Given this list of marker genes BRIX1, ASB8, PRELID2, SMPD4, ENOPH1, EXOSC3, CHIA, TMEM100, CTPS1, FUT11, HCAR2, ARV1, SERPINF1, KBTBD7, TNK1, ABCB6, GPR83, MRPL22, COQ4, YRDC, MT2A, NHLRC2, BTK, ATAD1, GPR89B (G protein-coupled receptor 89B), IVD, ECD, ZNRD2, MKX, PDCD1, DRC12, CLCN4, PES1, POLR3E, BOD1, VDAC1, CUL5, RWDD4, RBMXL1, MFSD3, HDAC3, MOBP, ZNF638, RNF113A, IMPG1, JCAD, PCLAF, PLEKHA6, QNG1, C1S, PRMT7, GPR37L1, C1orf216, TXNL4A, RBBP4, PAPOLA (NCBI Gene Id 84718), PFN1, RBBP7, DLD, POLA2, PDF, HDAC1, FGFBP1, NRSN1 (neurensin 1), LIPT1, COL6A5, SOCS1, LIPT2, FEN1, LTB, MTF2, POP7, YTHDC2, TFAP2E, DEFB119, NDUFAB1, OTOP2, TMTC4, HPRT1, AKR7A2, HASPIN, SLC39A1, MRPL19, RUVBL2, SLC2A3, ORC6, IRGM, ERG28 (ergosterol biosynthesis 28 homolog), UBL3, C6orf58, LYAR, CCDC86, WDR77, SOWAHC, DBR1, PPP1R7, EXOSC1 (exosome component 1), SLC30A2, B3GNT2, SRSF6, PSMC2, POLR2D, SUV39H2, BCKDK, LIG1, RARS1, EIF5A2, ORAI1, TP73, RPUSD3, TYSND1, USP39, C5orf47, USP1, PRMT5, IPO11, SLF1, CDC34, CHAC2, RNF180, CRLF3, EIF4A1 (eukaryotic translation initiation factor 4A1), TBRG4, PRKAG2, MGAT3, CIMIP5, LIPG, ANXA4, TUBA4A, ZNF81, BCL2A1, SBNO1, PLCD1, TFAM, POLR1E, HEBP1 (heme binding protein 1), B3GALT2, FABP5, PPHLN1, RMDN3, MRPS31, PSAT1, HCCS, LSG1, CERCAM, POGLUT3, TKTL2, TNFRSF4, RRP15, NRROS, CTSW, TMEM229B, NDUFAF4, INO80E, MRPL46, ATP6AP2, NSDHL, VN1R5, PTPN6, GIPC1, SFTPA1, GJA1, ST7, AAMDC, PYCR2, CLIC4, CD164L2, MRPL12, ATP23, IFT57, AARSD1, NDUFA9, MANBA, RTF2, EXOSC2, PSMD13, SH2D2A, DNAJC5B, CSAD, IPO9, CHST13, APRT, METTL2B, IFI35, ERH, TNFRSF18, CASK, CHIC2, RNF135 (ring finger protein 135), TET1, AP1S1, DIAPH3, UXS1, SLC7A6, DCST1, ADSL, PSMB3, BIRC5, B3GALT6, LIMD1, here is a description of the gene set: The aim of this study was to employ a systems-level analysis to elucidate gene expression networks operating in the CD4 T-cell responses which underpin human atopic disease. Genes down-regulated in CD4 T cells stimulated with allergen (house dust mite): atopy versus healthy. from publication Bosco A, McKenna KL, Firth MJ, Sly PD, Holt PG (PMID 19414752) Human Gene Set: GSE14908_ATOPIC_VS_NONATOPIC_PATIENT_HDM_STIM_CD4_TCELL_DN studied in species Homo sapiens